Given this list of marker genes FAH, APOA2, MASP2, ECHS1, TAT, VTN, ZG16, ABCC6, PCK1, AMBP, CES1 (NCBI Gene Id 1067), GSTZ1, CEBPA, C4BPB, APOC1 (apolipoprotein C1), CYP27A1, ADH1C, PXMP2, HP, ITIH3, C2, ASGR1, CDHR5, C8G, GNMT, ADH6, CYP1A2, CES2, DCXR, PLG, TST, HAAO, CYP2C8, APOF, TKFC, SARDH, ORM1, AKR1D1, CIDEB, GJB1, HABP2 (NCBI Gene Id 3026), ALDH4A1, SERPINC1, SLC22A1, ALB, ORM2 (orosomucoid 2), SERPING1, CFHR4, CYP2C9, F12, CFB, GAMT, G6PC1, HPD (4-hydroxyphenylpyruvate dioxygenase), NNMT, RARRES2, ITIH1, F10, SERPINF2, TMEM176B, SPP2, ASGR2, CPB2, HSD17B6, C6, IGFALS, C3, ALDH1L1, MAT1A, HMGCL, ASL, LCAT, GSTM2, ANGPTL8, PROC, UPB1, AKR7A3, SDS, SAA4, AGXT, SLC38A3, CYP4F2, AGT, HAMP, FTCD, TMEM176A, ACOX2, HPX, APOC4, KHK, SLC22A7, SLC10A1, APOH, PEMT, APOC2, ATF5, SERPINA6, SLC27A5, ZGPAT, CYP4F12, CPN2, C4BPA, CYP4F11, RBP4, AHSG, F2, RDH16 (retinol dehydrogenase 16), ANG, APOC3, ALDOB, HMGCS2, ITIH4, CYP2A6, GSTM1, HPR, SERPIND1, PON3, HRG, PIPOX, APOA1, TMPRSS6, HGFAC, TM4SF5, HPN, SERPINA4 (NCBI Gene Id 5267), C8B, CYP2E1, CYP4A11, CYP2D6, APCS, CYP2B6, LECT2, C8A, PON1, FETUB, here is a description of the gene set: Human Gene Set: GNF2_HPX species: Homo sapiens Neighborhood of HPX Neighborhood of HPX hemopexin in the GNF2 expression compendium